Given this list of marker genes Zbed6, Gata1 (NCBI Gene Id 14460), Ipo7, Wnt3, Synj2bp, Smarcc1 (NCBI Gene Id 20588), Bicral, Bglap2, Vhl, Mir669a-9, Xdh, Tlr2, Kremen1, Gdf15, Cyth2, Ing1, Lrig2, Noct, Foxp1, Nrarp, Wnt1, Lbx1, Clstn3, Thy1, Serpinf1, Bmyc, Tie1, Ppp3ca, Cdk6, Bcl6, Vash1, Ptpn11, Six2, Smarca4, Grin3a, Hhex, Tex11, Socs5, Angptl7, Areg, Zeb1, Rtn4r, Ccr1l1 (NCBI Gene Id 12770), Trim72, Krit1, Abcg1, Mixl1, Wee2, Suds3, Minar1, Itgb1, Tek, Ptger4, Fermt1, Rgs4, Ctdsp1, Stc2, Nanog, Ski, Yjefn3, Dnmt1, Cd36, Kit, Hlx, Fgf3, Actb, Stard13, Pglyrp1, Fbln5, Cga, Tll2, Ubash3b, Lmo2, Tbx5, Cul4a, Emilin1, Crhr2, Mir669a-6, Oog2, Ccl3, Wnt4, Foxj2, Ctdp1, Cysltr2, Mir669a-4 (NCBI Gene Id 100526535), Thbs1, Glis1, Ggcx, Tmem119, Apoe, Dlx1, Spry1 (NCBI Gene Id 24063), Carlr, Ptprm, Socs2, Axin1, Sap30l, Adgrb3, Sema4f, Optc, Fuz, Spred3 (NCBI Gene Id 101809), Bcl7b, Lrp4, Notch3, Ctnnb1, Sra1, Runx3, Vgll4, Tbx3, Eif4e, Klf7, Sema4d, Cited2 (Cbp/p300-interacting transactivator, with Glu/Asp-rich carboxy-terminal domain, 2), Gpr137b, Rnf6, Ddb1, Tgfb1i1, Idh2, Sox6, Dll3, Srgn, Tcf15, Mul1, Kctd11, Wnt5a, Pthlh, Trpc5, Cnmd, Zfpm2 (zinc finger protein, multitype 2), Actl6a, Sap30, Zbtb46, Zfp354c, Klf2, Ccn4, Shb, Ndfip1, Kcnk2, Fuom, Trim46, Kras, Tbx2, Mdga1, Sox4, Agt, Thoc5, Hgs, Hoxb8, Shh, Efnb3, Klf4, Fgf8, Spred1, Pias3, Ythdf2, Trak2, Smo, Ube3a, Kat8, G6pdx, Tmem64, Notch1, Rpl3l, Ifng, Rorb, Inhba, Fbxo11 (F-box protein 11), Myc, Ccn3, Mir133a-1, Sox21, Trib1, Kank1, Creb3l1, Nfatc4, Nkx6-1, Mir669a-7, Shoc2, Adgrb2, Cd24a, Dicer1, Sinhcaf, Gdf3, Pglyrp3, Pawr, Sulf1, Tsc2, Cntn2, Parp1, Fbxw7, Klf13, Cfl1, Myocd, Sin3a, Rgs2, Coro1b, Fgf13, Sort1, Cd86, Fyn, Extl3, Diaph2, Ush2a, Nbn, Epha4, Ptger3, Cd160, Cd44, Zbtb7b, Rhoa, Trpc6, Ostn, Rgn, Tmem215, Pth, Reg3a, Prdx2, Fbn1, 4930550C14Rik, Gadd45a, C1qc, Gas6, Snai2, Egfr, Arhgef15, Pira1 (NCBI Gene Id 18722), Bex1, Mir214, N4bp2l2, Atg16l1, Rufy3, Gpr137, Aspm, Sox15, Ttc3, Smad4, Adipoq, Sars1, Irx3, Rela, Ddit3, Laptm5, Ccdc85b, Asxl1, Smarcd1, Mapk11, Nos3, Mfn2, Thbs2, Cdh1, Gabpa, Zfhx3, Cntf, Gpr171 (NCBI Gene Id 229323), App, Yap1, Pten, Dpysl5, Flt3, Kifap3, Tlcd3b, Mark1 (MAP/microtubule affinity regulating kinase 1), Rc3h2, Vegfa, Fasl, Bglap, Pramel7, Dab2ip, Ss18, Il2, Mepe, Tpt1, Tnr, Zfp418, Sox10, Spred2, Brinp1, Rara, Trp63, Btg2, Adamts12, Gper1, Zfp296, Rbpms2, Vasn, Arhgap4, Tgfb2, Zfp750, Csrp3, Gnas, Rbbp7, Nfe2l2, Sostdc1, Srsf6, Hdac6, Rbpj, Draxin, Ccr1 (NCBI Gene Id 12768), Reg3g, Inpp4b, Jak3, Grb14, Nmrk2, Mir7-1, Rora, Stat5b, Ltf, Zfp536, Dll1, Lyn, Sox2 (SRY (sex determining region Y)-box 2), Calr, Ptbp1 (polypyrimidine tract binding protein 1), Ovol2, Mesp1, Qki, Rag2 (recombination activating gene 2), Myoz1, Plxna3, Lrp6, Il6 (interleukin 6), Mag, Rtn4rl1, Socs1, G6pd2, Rap1gap, Nf1, Hrg, Riox1, Spart, Ppard, Foxj1, Rspo2, Anp32b, Abr, Ntn1 (NCBI Gene Id 276903), Cib1, Pf4, Insl6, Cdkl3, Cd59a, Mecp2, Ctnna1, Epha2, Dlk1, Pax8, Tomm70a, Trpv1, Bcl2l1, Slit2, Appl2, Ifnb1, Trp53, Mt3, Prmt1, Mapt, Dtx1, Enpp1, Sparc, Six3, Mir329 (NCBI Gene Id 723842), Fst, Nbr1, Tmem53, Tnmd, Carm1, Stk11, Itpkb, Col4a3, Bmp4, Tmem131l, Spsb3 (NCBI Gene Id 79043), Plpp7 (phospholipid phosphatase 7 (inactive)), Igf2, Wnt9a (wingless-type MMTV integration site family, member 9A), Nox1, Lbh, Grem1, Ptch1, Fndc3b, Trim11, Lgmn, Ephb1, Ywhah, Col5a1, Ppara, Tmsb4x, Ngef, Mir30c-2, Abca5 (NCBI Gene Id 217265), Sema4a, Sap130, Tnpo2, Adipor1, Dtnbp1, Ascl1, Cdk13, Runx1, Serpine1, Rbp4, Mir137, Id2, Tlx3, Sema3a, Ptpn6, Adamts9, Gdi1, Crim1, Spry2, Efna1, Ptpn13, Rarg, Zfp36l2, Ngfr, Actl6b, Sorl1, Pdcd4, Spag9, Ism1, Mettl14, Dnajb11, Esrrb, Fbxo7, Ncor2, Mir448, Ccl2, Rflna, Dynlt1b, Pdgfb, Il4ra, Pax2, Cav1, Tgfbr1, C1ql4, Gpr55, Cd69, Skic8, Tcf4, Hbp1, Ctr9, Cdh3, Twsg1, Ybx3, Tnfaip6, Usf3, Cyp27b1, Gli3, Dnm3, Hes1, Prmt5, Nfatc3, Bcl11a, Cdkn1b, Tcf23, Lilrb4b, Nkx2-5, Hdac5, Sh2b3, Col4a2, Cit, Foxc2, Rarb, Rb1, Pik3cb, Slc12a2, Ncoa3, Cdk5, Pak1, Ptprs, Nras, Plg, Id4, Vdr, Slc7a10, Huwe1, Foxo4 (forkhead box O4), Hnrnpu (heterogeneous nuclear ribonucleoprotein U), Ccl9, Bbs2, F2, Dnm1l, Efemp1, Lin28a, Oog1 (oogenesin 1), Cdkn2a, Foxo1, Foxa1, Rapgef2, Apc, Mgarp, Mir669a-8, Brd9, Hey2, Wdr77, Prdm6, Sema3e, Lhx2, Nr1d1, Cftr, Bbs12, Sema3g, Foxe3, Disp3, Nodal (NCBI Gene Id 21792), Ccn6 (cellular communication network factor 6), Adgrb1, Hnrnpk, Naxe (NAD(P)HX epimerase), Cpe, Pilrb1, Ube2b, Cst3, Abcc8 (ATP-binding cassette, sub-family C member 8), Ptpn2, Il18, Mdk, Trim6, Sav1, Arid4b, Med1, Dlx2, Tbx6, Rflnb, Pgk1, Sema5a, Hhip, Sod2, Sod1, Asap1, Cbfb, Prkn, Cxcl10, Rc3h1, Fezf2, Akirin1, Dspp, H19, Fzd7, Hey1, Prl7d1, Pcid2, Trp73, Hmga2, Dkk4, Anxa1, Cntn4, Sema3f, Ppargc1a, Spdef, Mstn, Sycp2, Crp, Ddx6, Tgfbr3, Tcta, Mir669a-5, Hyal3, Fermt2, Twist1, Nelfb, Il4, Hnf1b, Angpt4, Tmem182, Bmal1, Dact3, Alms1, Bmp7, Ryk, Luc7l, Lef1, Pik3r1, Pml (NCBI Gene Id 338524), Pou4f2, Ulk1, S2bpcox16, Chrd, Ptk2b, Gsk3b, Hopx (NCBI Gene Id 74318), Ccr2, Pinc, Wnt10b (NCBI Gene Id 22410), Ldlr, Mir669a-3, Alpk2, Tnf, Bicra, Wnt7b, Mir205, Diaph1, Ptgr3, Lilrb4a, Angpt2, Il17rd, Hmgb3, Fmr1, Mbnl3, Nucb2, Apoh, Wnt7a, Prdm16, Ifrd1, Arpin, Myb, Prickle1, Cdk5rap2, Nf2, Gsdma3, Cldn18, Iqcb1, Gata2, Men1, Igfbp5, Nphp3 (nephronophthisis 3 (adolescent)), Ccnk, Tjp2 (NCBI Gene Id 226034), Lif, Inpp5d, Ereg, Oog3, Syt4, Mmp9, Zfpm1, Tnn, Phf14, Hook3, Eid2b, Gfi1, Stk4, Dsg2, Cited1, Trp53inp1, Ctla4 (cytotoxic T-lymphocyte-associated protein 4), Bcl7c, Pglyrp2, Gsk3a, Tacstd2, Limd1, Tunar, Iapp (NCBI Gene Id 15874), Trpm4, Fas, Pkp2, Stab1, Ybx1, Sema6a, Col5a2, Lrp5, Nkx3-2, Gpr37l1, Cebpa, Dmd, Aspn, Meis2, Neurod2, Hes5, Mfn1, Zc3h8, Gpr68, Asmt, Acvrl1, Hdac8, Nfatc1 (nuclear factor of activated T cells, cytoplasmic, calcineurin dependent 1), Vax1, Mib1, Dcn, Adcyap1, Pdcd1, Bcl2, Irf1, Rtn4, Rps6ka6, Pramel1, Ctsk, Sox9, Apbb1, Lgals1, Wt1 (NCBI Gene Id 319408), Pou5f1, Foxp4, Bcr, Stk3, Ago1, Jarid2, Mafb, Prl2c2, Vegfc, Eaf2, Nlgn1, Pparg, Gpr4, Nkx6-2, Mir133b, Cxcl14, Ypel4, S1pr3, Sema6c, Bnip3, Adamts7, Pink1, Tafa5, Hand2, Vat1, Clec2d, E2f1, Tgfbr2, H2-M3, Nepro, Epha7, Trem2, Hoxa9 (homeobox A9), Mir217, Rbbp4, Zfp608, Tcf7l2, Slc6a4, Hspa9, Dkk1, Bdnf, Suz12, Bmp2, Stat5a (NCBI Gene Id 20850), Ezh2, Mir135a-1, Rgcc, Mir204, Amot, Rock2, Tmem176a, D130043K22Rik, Robo1, Runx1t1, Apcs, Rest, Lsm1, Parp3, Spi1, Prox1, Pira12 (NCBI Gene Id 18730), Cdc73, Rock1, Cldn5, Wnt9b, Tnfsf18, Ccl17, Elapor2, Cartpt, Id3, Ccl11, Zfp706 (NCBI Gene Id 98236), Il36g, Mad2l2, Nkx3-1, Nmnat1, Ldb1, Pbx1, Ccnd1, Kdm1a, Amh, Sfrp1, Bmpr1a, Smarca2, Axin2, Usp2, Fstl3, Hdac9, Ednrb, Osr1 (odd-skipped related transcription factor 1), Eif2ak4, Smad6, Ptk2, Phox2b, Lag3, Tgfb1, Bmpr2, Xbp1, Atoh1, Brms1, Nkx2-2, Fgf23, Bhlha15, Nfkbid, Cflar, Igf1, Flcn, Ascl2, Paf1, Tfrc, Atf5, Jag1, Prtg, Clec2g, Tnfsf4, Ankrd26, Mir30c-1, Gdf5, Sdhaf2, Map4k4, Dixdc1, Ulk2, Sall1, Nkx6-3, Ihh, Sirt2, Ccr5, Foxc1, Cmtm5, Dleu2, Pde3b, Rai1, Epn1, Ccnd2, Lingo1 (leucine rich repeat and Ig domain containing 1), Smad7, Lmna, Ranbp3l, Cbln1, Tmem178, Olig2, Adrb1, Drd3, Nkx2-1, Zhx2, Bcl7a, Frs2, Clec2i, Zfp36l1, Ntrk3, Gtf2i, Sfrp2, Erfe, Arhgef2, Actr3, Ltbp3, Lmx1a, Ucma, Casz1, Psen1, Hmg20a, Daam2, Mir23a, Itgb3, Hdac4 (NCBI Gene Id 208727), Mir669a-10, Nlgn3, Bhlhe23, Lep, Med28, Loxl2, Stat3, Bambi, Mbp, Chadl, Ccl21b, Tlx2, Ttpa, Atxn2, Tsc22d1, Hdac3, Arf6, Dab1, Pi16, Nfib, Isl1, Mir154, Cav3, Gdf11, Irgm1, Stat1, Trpv4, Atf2, Mir1a-2, Mir133a-2, Vsx2, Foxa2, Flt1, Hoxa2, Shc1, Daxx, Plk2, Nog, Tob2, Eif4enif1, Arid4a, Adrb2, Meis1, Dusp10, Zfp36, Hdac1, Hif1a, Tnfrsf11b, Mkx, Fgf10, E2f2, Gli2, Slit1 (slit guidance ligand 1), Foxo3, Leo1, Lrp3, Xylt1, P2ry12, Foxp3 (forkhead box P3), Mir669a-1, Rcan1, Kdm4a, Dpf2, Trib2, Il17d, Slc4a2, Bhlhe41, Cd74, Itgav, Nr5a2, Wwc1, Gata3, Erbb2, Tbx1, Efna3, Ogt, Gps2, Fstl4, Msx1, Clec12a, Ankrd17, Hspb1, Gja1, Idua, Nfe2, Fgfr1, Pitx3, Clec4g, Sfmbt1, Mycn, Foxg1, Loxl3, Epn2, Ing2, Sox11 (SRY (sex determining region Y)-box 11), Sema6d, S100b, Pcm1, Adgrv1, Chad, Trib3, Inpp5f, Csf1r, Dip2b, Wwtr1, Mapk1, Nme1, Map2, Zfp932, Mir125a, Snai1, Ptprz1, Cers2, Sox3, Fxn, Oma1, Rbm10, Fgl2, Yy1, Neo1, Frzb, Spinkl, Sox8, Rgma, Il1b, Zfp35, Six4, Fgf9 (fibroblast growth factor 9), Cer1, Trio, Mir338, Ppp2ca, Ahsg, Tmem98, Adrb3, Tert, Rnf10, Wwc2, Cdkn1a, Jdp2, Mael, Tbx21, Atp2b4, Usp19, Tob1, Cdk12, Hpn, Rbm15, Isl2, Cxadr, Mir669a-2, Il17f, Skil, Tent5c, Smad3, Pax6, Id1, Lrrc17, Gorasp1, Twist2, Fat3, Nppc, Mmp11, Cxcr3, Ecm1, Elf5, Tsku, Thbs4, Brms1l, Ptn, Nr2e1, Msx2, Nrp1, Hmgb1, Cdkn2b (cyclin dependent kinase inhibitor 2B), Smad1, Ceacam1, Nfkbia, Trim62, Tmem176b, Ephb2, Npr2, Nfatc2, Notch4, Adck1, Zc3h12a, Ldlrad4, B2m, Hdac2, Rapgef3 (Rap guanine nucleotide exchange factor (GEF) 3), Mbd1, Adamts1, Hoxa7, Tet1, Plac8, Ecscr, Wnt3a, Il1a, Insig1, Nr5a1, Bcor, Ahr, Syngap1, Ankrd2, Ngp, Alox5, Sirt1, Rtca (RNA 3'-terminal phosphate cyclase), Nme2, Ofd1, Pglyrp4, Hdac7, Tspo, Fgfr3 (fibroblast growth factor receptor 3), BC037156, Hoxa5, here is a description of the gene set: Mouse Gene Set: GOBP_NEGATIVE_REGULATION_OF_DEVELOPMENTAL_PROCESS Any process that stops, prevents or reduces the rate or extent of development, the biological process whose specific outcome is the progression of an organism over time from an initial condition (e.g. a zygote, or a young adult) to a later condition (e.g. a multicellular animal or an aged adult). species: Mus musculus